Given this list of marker genes APBB2, LIPH, BMP2K, WDR37 (NCBI Gene Id 22884), SYTL2, OR11A1, ADCYAP1, ZNF644, EIF2AK2, FGL2, SUMO2, TMEM150A, AP2B1, ZNF143, COG5, RGS7BP, TANC1, STOX2, HTR2C, LVRN, GID4, KCNB1, CTSC, ITGB1, CYP3A5, BRD8, SLC12A2, DIPK2A, ARK2N, ACP6, TMEM167B, DRD1, CTDSPL2, PLRG1, NEK2, USP34, SGK3, RAD21, here is a description of the gene set: from publication Chen Y, Wang X (PMID 31504780) studied in species Homo sapiens Human Gene Set: MIR3157_3P Genes predicted to be targets of miRBase v22 microRNA hsa-miR-3157-3p in miRDB v6.0 with MirTarget v4 prediction scores > 80 (high confidence targets).